Given this list of marker genes CAMK1, CAMKK1, GIT1, RAC1, CALM1, CAMKK2, ARHGEF7, here is a description of the gene set: species: Homo sapiens Human Gene Set: REACTOME_ACTIVATION_OF_RAC1_DOWNSTREAM_OF_NMDARS Activation of RAC1 downstream of NMDARs